The following is a description of a gene set: studied in species Homo sapiens Human Gene Set: HP_RECURRENT_SYSTEMIC_PYOGENIC_INFECTIONS Increased susceptibility to systemic pyogenic infections, as manifested by recurrent episodes of systemic pyogenic infections. Recurrent systemic pyogenic infections, and this is the list of marker genes: SEMA4D (semaphorin 4D), GPR35, TCF4, LYST, MST1